Given this list of marker genes IGF2BP3, FRMD6, BBS9, JADE1, NR2C1, ATP5PO, ADCK5, METTL2B, DAG1, STX1A, CCNQ, P4HA1, EXTL2, RALGPS2, IZUMO1R, DNAJB4, ALDH2, SATB1, WASHC4, CYTH2, TRAT1, FAM78A, ABHD14A, NT5C, GOLM2, TMEM31, MCMBP, RASSF8, OSMR, SENP7, ABCG2, CRISPLD1, PRKD2, ATP1B3, KDM5B, DLEU7, FAM3C, ITM2A, FBXL3 (F-box and leucine rich repeat protein 3), CD28, CITED2, AGO1, SARAF, NGRN, QPRT, SLC35D1, SYCP2L, SNX4, EIF1 (eukaryotic translation initiation factor 1), PIK3IP1, C2orf42, DYRK2, NTN4, PTK2, SMARCA2, TOP2B, RNF182, SETX, TRIML1, TMEM106B, KRT86, SPACA7, IL7R, PDLIM1, BTBD7, MSRB2, ZNF250, TSC22D1, HNRNPK, GGT7, EMP1, LPCAT4, CPQ, GCKR, CPB1, TSC1, TSACC, SLAMF6, ARRDC3, STT3B, GLUL, SMC4, SUSD1, NDRG2, WDFY3, ACTN1, PRKAG1, CACNA2D4, SLC36A4, HIBADH, DAPL1, CCDC125, SCAF4, SLC7A8, MRPL23, CHD2, RDH14, ORAI2, SKOR1, ADH1C, LDLRAP1, LYPD1, OAZ2, TMEM158, BRAF, VKORC1, F2RL1, ZNF202, SLC23A3, EXPH5 (exophilin 5), NOB1, FAM168A, CEBPZ, PRODH, TSSK4, ANKRD13C, CYP2D6, SLC3A1, LDLRAD4, F2, MCOLN3, ADIPOQ, LMO4, PJA1, SLC25A27, TMEM108, S1PR1, GPD1L, GFOD2, USP2, ZBTB10, EPHX1, OSBPL9, PLAGL1, VMAC (NCBI Gene Id 400673), CTDSP2 (CTD small phosphatase 2), ACADM, TRIB2, SPRY1, TECPR1, DNTT, ZNF22, RPL22L1, ASGR1, IPO4, INSR, SUSD4, BCL2, ATP6V0D2 (NCBI Gene Id 245972), CSNK1E, TMEM71, SKAP1, GUCY1A1, THRAP3, PIK3CD, TEX10, URI1, FGD3, INTS6, TSPYL5, SPOCK2, ZNF592, PPP1R1B, RHOH, MFHAS1, CREBL2, SPACA1, VIPR1, MLH3, HIVEP3, CCS, HSD17B11, BEND6, TMLHE, ZNF623, CNKSR3, POLR3F, IGF1R, OTUB2, ATF7IP, ZIC4, SSH2, HEXIM1, PGAP1, KLHDC2, RAPGEF4, TP53, USP28, LCLAT1, FITM2, MORN3, ARHGEF11, UBE3D, PAF1, MAN1A1, PPDPF, LYPD6B, RC3H1, KIAA0930, LPL, here is a description of the gene set: In innate immune responses, activation of Toll-like receptors (TLRs) triggers direct antimicrobial activity against intracellular bacteria, which in murine, but not human, monocytes and macrophages is mediated principally by nitric oxide. We report here that TLR activation of human macrophages up-regulated expression of the vitamin D receptor and the vitamin D-1-hydroxylase genes, leading to induction of the antimicrobial peptide cathelicidin and killing of intracellular Mycobacterium tuberculosis. We also observed that sera from African-American individuals, known to have increased susceptibility to tuberculosis, had low 25-hydroxyvitamin D and were inefficient in supporting cathelicidin messenger RNA induction. These data support a link between TLRs and vitamin D-mediated innate immunity and suggest that differences in ability of human populations to produce vitamin D may contribute to susceptibility to microbial infection. studied in species Homo sapiens Genes up-regulated in monocytes (6h): untreated versus M. tuberculosis 19 kDa lipopeptide. from publication Liu PT, Stenger S, Li H, Wenzel L, Tan BH, Krutzik SR, Ochoa MT, Schauber J, Wu K, Meinken C, Kamen DL, Wagner M, Bals R, Steinmeyer A, Zügel U, Gallo RL, Eisenberg D, Hewison M, Hollis BW, Adams JS, Bloom BR, Modlin RL (PMID 16497887) Human Gene Set: GSE8921_UNSTIM_VS_TLR1_2_STIM_MONOCYTE_6H_UP